The following is a description of a gene set: species: Mus musculus The formation of a protein dimer, a macromolecular structure consists of two noncovalently associated identical or nonidentical subunits. Mouse Gene Set: GOMF_PROTEIN_DIMERIZATION_ACTIVITY, and this is the list of marker genes: H2ac10, Hspb8, Mga, Foxp2, Mef2d, Mmaa, Septin12, Ggct, Bmal2, Inpp5f, Erp29, Slc5a5, Nr0b1, Ntrk2, Ncoa3, Aimp1, Syt3, Ascl2, Defa2, Mesp1, Trim8, Sri, Cylc1, Impa1, Nr2f2, Tyms, Defa41, Defa30, Tox3, Smim1, Tpst2, Uxs1, Mad2l1, Tcf3, Micu1, Pml, Il12a, Rbpms, Gsta13, Nhlh2, Pdgfa, Gldc, Coq9, Alx1, Gid8, Map3k5, Snx6, Map3k13 (NCBI Gene Id 71751), Upb1, Ano4, Abtb3, Kcnk3 (potassium channel, subfamily K, member 3), Eif2ak1, Gpd1l, Tpr, Agr2 (NCBI Gene Id 23795), Casq2 (calsequestrin 2), Nlrc4, Nrbp1, Odc1, Cib2, Trim9, E2f4, Fech, Arnt, Cgas, Adrb1, Tbc1d22a, Tlr4, S100a1, Srebf2, Bmal1, Ptprt, Park7, Ahrr, Hvcn1, Tfap4, Qtrt1, Ccdc88c, Defa22, Atp1b1, Lrrk2, Hpgds, Taf6l, Smad4, Camk2g, Gstz1, Ncoa2, Sohlh1, G6pdx, Ppcs, Ceacam2, Helt, Kcnn4, Nfe2l1, Cyp2r1, H2ac8, Pik3r2, Id1, Mgll, Mlx, Supt4a, Lct, Pip4k2b, Pheta2, Gstm1, Adcy8, Vwa1, Tert, Nr2c1, Glipr2, Asmt, Abcg5, Fxr2, Tsc2, Smc1a, Bak1, Dgat2, Cebpb (CCAAT/enhancer binding protein beta), Cars1, Ripk1, Col9a3, Cep135, Rabep1 (rabaptin, RAB GTPase binding effector protein 1), Tyrp1, Ascl1 (NCBI Gene Id 17172), Mitf, Cpq, Atf2, Hsd11b1, Col9a1, Amelx, Serpinf2, E2f6, Hoga1, Zbed6, Galm, Ralgapa1, Ano2, Krt1 (NCBI Gene Id 223916), Tkt, H2ac20, Bhlhe23, Tgfb2, Gucy2e, H2-Q6, Hes5, Tpm2, Gphb5, Rragc, Ece1, Epas1 (NCBI Gene Id 13819), Cryab, Syndig1, Pdgfra, Tpm1, Hes1, Slc51b, Nlgn4l, Wwtr1, Pank1, Ano1, H2al2a, Thra, Tyrobp, Lrp6, Neurog2, Tap2, Nhlh1, Tcf12, Ceacam1, Tenm1, Flt4, Blm, Phb2, Exd2 (NCBI Gene Id 97827), Zfp174, Dars2, Drosha, Nae1, S100b, Slc25a27, Olig3, Ppp3ca, Tars2, Tnnc1, Psmf1, Atic, Cenps, Cadm1, Macroh2a1, Mkln1, Ywhae, Tfap2b, Cst7, Izumo1, Mtmr1, Dapk3, Pdss2, Bhlhe22, Defa31, Rag1, Tcf23, Abcb9, Gale, Mag, Appl2, Mid2, Morc2a, Ikzf3, Gdnf, Pkd2, Ikbkg, Macroh2a2, Adam10 (NCBI Gene Id 67314), Defa20, Polr1d, H2ac25, Pank3, Ang4, Gstm3, Omg, H2ac15, Cidea, Kif20b, Myh9, Ang6, Slit2, Id2, Agxt, Defa26, Irak3, Gsta5, Micu3, Alpi, Pdxp, Nudt16, Meiosin, Hes3, Slc7a8, Trim37, Ercc5 (NCBI Gene Id 22592), Mnt, Flt1, Tbx1, Rpe, Cd4, Bax, Pglyrp3, Nr4a1, Casr, Zhx1, Ralgapa2, Atp1a2, Defa21, Cav1, Nod1, Trex2, Gbp2b, Dsg3, Shmt1, Ang2, Kcnn2, Lyl1, Slc25a14, Katna1, Slc30a8, Uba2, Aox4, Zbed4 (zinc finger, BED type containing 4), Scarb2, Chrna7, Camk2d, Hand2, Dnttip1, Plekhb1 (NCBI Gene Id 27276), Fut9, Gtf2a2, Nr4a2, Jchain, Heyl, H2-T22, P4hb, Syt5, E2f5, Defa38, Vapb, Tenm2, H2ac22, Acod1, Endog, H2az2, Crppa, Elavl1, Mesp2, Ptgs2, Thap12, AY761185, Grpel1, Bnip3l, Ext1, Hif1a, Sgta (NCBI Gene Id 68091), Pafah1b2, Fbxo4, Ano5, Ces1b, Rnf8, Bard1, H2bc22, Tppp, Glud1, Ghr, Trp53bp2, Myog, Syt6, Lsm7, B2m, E2f1, Dab2ip, Gla, Cryl1, Supt7l, Setmar, Pheta1, Hey2, Mtpap, Enpp1, Nectin3, Slc8b1, Msh2, Taf9, Pef1, Pex7, Supt4b, Mtus2, H2ac21, Tcf4, Defa34, Bhlhb9, Mid1, Nfs1, Il12b, Atoh7, Tsg101, Zdhhc3, Snrpc, Hsd17b4, Adra1a, Calcoco2, S100a11-ps, Gabbr2, Pde2a, Knstrn, Ticam2, Gdf15, Krt25, Abcg3, Tenm3, Zdhhc2, Sephs1, Abcd3, Aldh1a3, Nectin1, Pon3, Kcnk9, Supt5, S100a6, Csn1s2b, Tlr6, Ccdc66, Defa32, S100a10, Grm7, Nadk2, Gss (glutathione synthetase), Cep57, Irak1, Figla, Ugt1a5, Chuk, Rilpl2, Lrrfip1 (leucine rich repeat (in FLII) interacting protein 1), Tal2, Uba3, Nrf1, Bhlha15, Btrc, Gstm5, Srr, Msgn1, Mef2c, Nudt16l1, Mzf1, Klhl7, Defa5, Aadat, Abcg1, Atoh8, Srm, Hars1, Pex11b, Ssbp1, Mmachc, Masp1, Gch1, Tbx15, Smchd1, Sds, Ficd, H2bc14, H2bc12, Mdh2, Stk25, Trim30b, Ppp3cb, Efr3a (EFR3 homolog A), Chrac1, Tap1, Mapk6, Sfpq, Bmp6, Mycs, Naa60, H2-Q10, Abcd2, Bnip3l-ps, Zfp397, Mthfd1l, Apoe, Uba5, Rom1, Eea1, Ugt1a7c, Dpy30, Fzd4, Dpp4, Foxp3, Aox3, Phb1, Taf13, Cer1, Qtrt2, Taf8, Apoa1, Arnt2, Neurod1, Thbs1, Stk10, Tarbp2, Prmt5, Acsl6, Taf12, Psmd7, Yars2, Npas2, Xkr4, Ppp2ca (protein phosphatase 2 (formerly 2A), catalytic subunit, alpha isoform), Taf3, Il17d, Myom3, Mbl1, Naaladl1, Neurog1, Ces1c, Cybb, S100a11, Cubn, Izumo3, Itga3, Pld6, Adrb2, Cant1, Aoc1, Trpc6, Gimap7, Fmr1, Grem1, Defa3, Il17f, Scx, Mcl1, Npm1, H2bc26, Prmt8, Pafah1b3, Rbpms2, Mgat2, Ache, H2-M3, Trim30d, Cav2, Pdk2, Plek, Clpx, Snf8, Zbtb4, Pik3r1, Chek2, Xcl1 (NCBI Gene Id 98422), Atoh1, Defa37, Mttp, Wdr54, Itgb1, Muc13, Npc1l1, Tmigd1, Kyat1, Nqo2, Nacc2 (NCBI Gene Id 98968), Pdcd6, Smc3, Ugt1a10, Mycl, H2bc18, Bhlha9, Xbp1, Cr2, Defa43, Acox2 (acyl-Coenzyme A oxidase 2, branched chain), Acp3, Vapa, Ferd3l, Ang, Gen1, Bhlhe41, Epm2a, Bcl11a, Camk2b, Timm9, Zfp318, Defa29, Npr3, Amhr2, Ccl5, Olig2, Slc33a1, Ugt1a6b (NCBI Gene Id 394435), Erbb4, Adra2c, H2az1, Nsmce1, Map3k12, Hand1, Eno1, Nkx2-5, Ddit3, Bok, Banf1, Ccl11, Dgkd, Commd1, Tcf15, Naga (NCBI Gene Id 17939), Card9, Fibin, Sdcbp2, S100a16, Sppl3, Thrsp, Stom, Parp1, H2-M10.1 (NCBI Gene Id 14985), App, Slc51a, H2-M10.2, Dusp29, Trim12a, Tfe3, Miga1, Spr, Kit, Sae1, Rnf40, Zfp365, Fgfr1, Prkra, Cacybp, Kcnip3, Nectin2, Creb3l3, Tpi1, Rap1gap (NCBI Gene Id 78775), Mvd, Kcnb1, Chka, Rchy1, Dnph1, Daxx, Hnf1b, Krt10, Nolc1, Sppl2b, Runx1, Lrp4, Mme, Xpnpep1, Padi2, Hif3a, Cyba, Prph2, Chmp4c, Septin5, Crym, Ptpro, Dnm1l, Apoa2, Fap, Hpd, Zbtb7b, Kcnk13, Sohlh2 (NCBI Gene Id 99608), H2aj (H2J.A histone), Ccdc88a, Atf3, Impa2, H2ax, Papss1, Hexa, Jam3, Usf1, Cdsn, Gbp2, H2ac7, Ripk2, Trmt112, Sh3glb1, Psg20, Abcg8, Pln, Fzd9, AU021092, Rack1, Tmem266 (transmembrane protein 266), Bloc1s6, St13, Iscu, Drap1, H2bc27, Ran, Scly, Bmpr1a, Hip1, Cby1, Pole3, Rab11fip2, Mmut, Nudt21, Ankrd11, Txnrd2, Ambp, Nog, Tuba1a, Pecam1, Zbtb38, Ern1, Grpel2, Cebpa, Clcn1, Sos1, Defa24, Cltrn, Snx9, Hes2, Defa23, Prps1, Dpyd, Npas4, Ttn, Tyw5, H3f3c, Defa25 (defensin, alpha, 25), Mstn, Zbtb16, Supv3l1 (NCBI Gene Id 338359), Thap1, Ugt1a6a, Txn1, Aldh3a2, Ruvbl2, Neurog3, Pirb, Abcg2, Abtb2, Fzd2, Stat1, Nr6a1, Hspb6, Pitx2, Actn1, Col9a2, Nars1 (NCBI Gene Id 98111), Mlxip, Ugt1a2, Tpd52l2, Efemp2, Usf2, St6gal1, Gsta1 (NCBI Gene Id 14857), Ikbkb, Gzma, Nsmce3, Stub1, Hnf4a, Syt4, Pcyt1a, Paxx, Rtn4, Rela, Gca, Nos2, Fbxo7, H2bc21, Schip1, Jdp2, Kcnb2, H2ac4, Cenpf, Dnm1, Vps25, Gstm4, Ano6 (anoctamin 6), Fbln5 (fibulin 5), Rab11fip3, Slc11a1, Mycn, Nscme3l, Gpha2, Twist1, Stat5b, Pkm, Aox1, Man2a1, Tfeb, Trp53, Ndp, Gstm2, Ntrk1, Ugt1a1, Tenm4, Siah1a, Sars1, Npas3, H13, Gsta2 (NCBI Gene Id 14858), Ctbp1, H2bc1, Dscaml1, Pdss1, Syt10, Sp1, H2-M5, Cpox, Vps4b, Hes6, Wars1, Cd247, Fzd1, Flna, Cip2a, Dgcr8, H2ap, Tubb2b, Inhbb, Hps1, H2-Q1, Ugt1a9, Csn1s2a, Ppp2r1a, H2-M2 (NCBI Gene Id 14990), Lyrm4, Cited1, Dclre1b, Ano7, Sos2, Gopc, Exd1, Snx2, Coro1a, Ide, Mef2a, Mfsd1, Nfyc, Syt1, Cadm3, Gbp3, Tpd52l1, Sting1, Xdh (NCBI Gene Id 22436), Prps2, H2ac24, Il10, Sp100, Slc7a13, St3gal2, Aoc1l3, Terf1, Bcas1, Agtr1a, Hook1, Rasip1, Birc5, Chmp4b, Pou3f3, Slk, Erbb3, Rrm2, Gtf2a1, Mgat4a, Sirt6 (sirtuin 6), Eng, Hsf1, Kynu, Gstm7, Pafah1b1, Srgap2 (SLIT-ROBO Rho GTPase activating protein 2), Ccdc103, H2ac12, Pycard, Myom1, Polr1c, Bcl10, Sod1, Tcf21, Jaml, Creb3, S100z, Eprs1, Smad3, Max, Pdcd10, Camk2a, Slc39a13, Agtr1b, Tlr9, Cda, Gstm6, Slc4a1, Top2a, Twist2, Mixl1, Itpr1, Defa17, S100a5, Katnb1, Oxa1l, Atp1b2, Fxr1, Adipoq, Hesx1, Defa40, Bltp3b, H2-M10.4, H2ac11, Tal1, Gnptg, Id4 (inhibitor of DNA binding 4), Irf3, Npas1 (NCBI Gene Id 18142), Bcl2, Adra2a, Defa42, Idh1, Ascl3, H2-D1, Clec2f, Miga2, Tpcn1, Rabl3, Pdxk, Gpd1, Mlxipl, Pnpo, Aoc3, Bnip3, Ropn1, Nfyb, Aifm1, Mettl3, Axin1, Glb1, H2-M11, Pdgfc, Sppl2a, Nr4a3, Clock (NCBI Gene Id 620729), Carnmt1, Cat, Add1, Trim12c, Cenpa, Fcer1g, F11r, Col2a1, Mxd4, Ang5, Aoc1l2, Actn4 (NCBI Gene Id 97354), Add2, Als2, Mxd1, Slc3a2, Erbb2, Kcnk1, Atp1a1, Eno1b, Lpl, Pdgfb, Dck, Grm6, Rraga, Trim5, Wrn, Hif1an, H2bc9, H2-K1, Stat3, Appl1, H2bc3, Golga5, Xpa, Sgtb, Map3k11, E2f2, Mxd3, Pip4k2a, Cbs, Abcg4, Trim30a, Prdm9, Trim30c, Abcb7, Psap, Pdlim4, Lsm5, Grhpr, Id3, Mxi1, Pgrmc1, Mecom, Kcnh2, Kcnk2, Acot7, Morc2b, Fbxw11, Tbx18, Dgkh, P2ry1, Dr1, Hsd17b1, Taf7, Mff, Pon2, Adrb3, Rcc1, Gbp5, S100a13, Zhx3, Akt1, Zhx2, H2ac23, Mtcl1, Xpnpep3, Stard3nl, Tmem192, Rilp, Tymp, H2-M10.6, Myf6, Gabbr1, Ncoa1, Ralgapb, Lsm6, Cln6, Tpd52, Aox2, Rbm44, Tfrc, Taf9b, Ext2, Stk26, Polr2j, E2f3, Olig1, Pth1r, Bdkrb2, Zbtb1, Ptpa, Terf2, Taf4b, Psph, Pole4, Slc3a1, Srebf1, Taf1, Neurod2, Micu2, Stk4, Taf6, Pglyrp4, Acvr1, Ocm, Myc, Grhl1, Kars1, Snx1, Kyat3, Hmox1, Myod1 (NCBI Gene Id 17927), Gyg1, H2-Q7, Ascl5, Ect2, Rragd, Diaph3, Cep131, G6pd2, Fgfr2, Tpst1, Tesc (tescalcin), Ldb1 (LIM domain binding 1), Sim1, Hnf1a (NCBI Gene Id 21405), Myf5, Slc7a9, Bhlhe40, H2ac6 (NCBI Gene Id 319164), Cenpt (NCBI Gene Id 320394), Atp2a1, Msi1, H2bl1, Pex11a, Mef2b (NCBI Gene Id 17259), Srf, Abcd1, Stk19, Timm10 (translocase of inner mitochondrial membrane 10), Slc26a5, Tyr, Hps4, Tmem132a, Sppl2c, Gars1, Aoc1l1, Atf4, Hhex, Syne1, Hsp90ab1, Rbm11 (RNA binding motif protein 11), Ugt1a8, Vil1, Csf1, Pdcd6ip, Ahr, Tfec, Il17a, H2ac13, Hspb1 (NCBI Gene Id 15507), Defa35, Tpm4, Ephx2, Irak2 (NCBI Gene Id 74787), Rab11fip4, Hip1r (huntingtin interacting protein 1 related), Cenpw, Flrt3, Ptf1a, Tcof1, Rilpl1, Prmt2, Ywhah, H2-Q2, Defa36, Cisd2, Mapk4, Ucp2, Adora1, Gadd45a, Rdh5, Pon1, Sox6, Cnot9, Msc, Bst2, Hmgcs1, Hsp90aa1, Hey1, Aurka, Sdcbp, Slc4a11, Trex1, Ano3 (NCBI Gene Id 99077), Stc2 (stanniocalcin 2), Klhl2, Cep43, Polr2c, Nr0b2, Neurod4, Atf6, Cdadc1, Cisd1, Acox1, Bud23, Dst, Kmt2a, Defa27, Il6ra, Abcb10 (ATP-binding cassette, sub-family B member 10), Nudt5, Defa28, Lhpp, Tssk4, Trnt1, Defa39, Neurod6, Atg7, Hes7, Chmp1a, Adra1b, Csf1r, Sim2, Stard3, Glce, Taf11, Apoa4